Given this list of marker genes SHROOM3, MYH4, ESPN, FRG1 (NCBI Gene Id 2483), PPP1R9B, VIL1, CFL2, SYNE3 (NCBI Gene Id 79686), CORO1A, AIF1 (NCBI Gene Id 9471), UXT, MYO1E, FSCN1, GAS2L3, CAPZA1, ACTR3B, SLC6A4, SPTBN5, KPTN (NCBI Gene Id 96493), MYO5A, SHROOM4, MYH6, CORO1B, TULP1, MYO1H, ABLIM2, NRAP, ADD3, ABLIM1, TPM2, ABL2, CTNNA3, AJUBA, CNN3, ABL1, CLMN, FLNB, MYH1, CNN1, MYO18B, TTN, ESPNL, PICK1, AFDN, HIP1, TAGLN3, MYO1F, CD2AP, POF1B, ADSS1 (adenylosuccinate synthase 1), MYO19, HIP1R, ACTN3, TNNI3 (NCBI Gene Id 7137), SCIN, MAP1S, TWF1, CNN2, MYO5B, DSTN (destrin, actin depolymerizing factor), GJB6, RCSD1, MYH8, MYO6, LASP1, TPM1, MYO10, MYO7B, ANTXR1, MYO15A, LIMA1, MYO1D, IQGAP2, FERMT1, MICAL1, PLEC, PPP1R9A, EZR, EPS8L3, TLN2, MYO1A, NEB, MYH11, GAS2L2, TRIOBP, XIRP1, TRPV4, ARPC5L, CORO6, AIF1L, CTNNAL1, BLOC1S6, MYO9A, AMOTL2, TPM4, CAPZA3, SPTA1, TMEM201, ARPC5, CORO2B, CAMSAP3, NEBL, ACTR3, HCLS1, PKNOX2, TNNC1, CAPZA2, ERMN, LUZP1, MYO1G, CACNB2, ABLIM3, EGFR, CTNNA1, MICALL2, ARPC2, CYFIP1, CORO2A, SPTBN2, TAGLN2, MYH13, ARHGAP27, MYH7B, PLS3, CAPG, CLASP2, ARPC1A, LRPPRC, FMNL3, ABI3, MYO18A, MYH9, NEXN, FLNC, ACTN4, ADD2, CFL1, FERMT2, ABITRAM, MYH10 (NCBI Gene Id 4628), MYH3, FMNL1 (formin like 1), ACTN2, PANX1, TWF2, XIRP2, PLS1, ACTR2, MYO5C, CORO1C, MYL4, ACTR3C, FSCN3, ADD1, MARCKSL1, ARPC1B, MYO9B, SPTAN1, CTNNA2, COTL1, CDK5R1, BIN1, LIMD2, MPRIP, MYO1C, MYH15, ARPC4, TLN1 (NCBI Gene Id 7094), IQGAP3, SAMD14, MYH2, SVIL, ARPC3, SPTB, MYO16, SYNE1, WDR1, SHROOM2, GAS2, FSCN2, SHROOM1, TPM3, SPTBN1, VILL, MYO1B, SPTBN4 (spectrin beta, non-erythrocytic 4), VPS16, DBNL, LCP1, MYO7A, MISP, KBTBD13, SHTN1, MACF1, MYH7, FMNL2, EEF2, MARCKS, IQGAP1, MYH14, GAS2L1, FHOD1, FLII, ITPRID2, PHPT1, DMTN, AVIL, FHOD3, ANXA8, GSN, ACTN1, FLNA, here is a description of the gene set: Human Gene Set: GOMF_ACTIN_FILAMENT_BINDING Binding to an actin filament, also known as F-actin, a helical filamentous polymer of globular G-actin subunits. species: Homo sapiens